Given this list of marker genes HMGB1, INS, PPP1R3B, ADCY10, PHKG2, PHKA1, PPP1CA, PPP1R3D, here is a description of the gene set: Human Gene Set: GOBP_REGULATION_OF_GLYCOGEN_CATABOLIC_PROCESS species: Homo sapiens Any process that modulates the frequency, rate or extent of the chemical reactions and pathways resulting in the breakdown of glycogen.